Given this list of marker genes Pla2g4b, Pla2g4d, Pla2g12a, Osbpl8, Pla2g10, Pla2g1b, Pla2g2a, Pla1a, Pla2g2f, Pla2g2e, Mboat1, Pla2g4e, Lpcat3, Pla2g4f, Lpcat4, Osbpl10, Pla2g5, Plaat3, Pla2r1, Osbpl5, Pla2g2d, Pla2g4a, here is a description of the gene set: Acyl chain remodelling of PS species: Mus musculus Mouse Gene Set: REACTOME_ACYL_CHAIN_REMODELLING_OF_PS